Given this list of marker genes Plekha8, Cln3, Psap, Pltp, Rft1, here is a description of the gene set: The directed movement of glycolipids, compounds containing (usually) 1-4 linked monosaccharide residues joined by a glycosyl linkage to a lipid, into, out of or within a cell, or between cells, by means of some agent such as a transporter or pore. studied in species Mus musculus Mouse Gene Set: GOBP_GLYCOLIPID_TRANSPORT